The following is a description of a gene set: Genes predicted to be targets of miRBase v22 microRNA hsa-miR-595 in miRDB v6.0 with MirTarget v4 prediction scores > 80 (high confidence targets). Human Gene Set: MIR595 from publication Chen Y, Wang X (PMID 31504780) species: Homo sapiens, and this is the list of marker genes: KIAA0753, RGN, ODC1, ZNF845, AKR1C2, TRAPPC13, CSMD3, IFNA14, SLC19A1, NTS, ETFRF1, HIVEP1, OGA, FAM227A, AFF4, PLD5, CLOCK, HINT1, UBE2G2, ARHGAP1, PPP3CA, BCAR3, NR2F2, DENND5A, ZDHHC13, CHM, SLCO4C1, UBASH3B, GAB4, CCDC85C, ECT2L, PPP1R21 (protein phosphatase 1 regulatory subunit 21), ZFP91, SH3YL1, SCLT1 (sodium channel and clathrin linker 1), CUL5, KIF21A (NCBI Gene Id 80819), KMT5A, COQ10B, IARS1, ADIPOR1, MTMR10, BNIP2, GABRA1, REPS2, ARMC8, OPHN1, HSF5, HAS2, BCKDHB, ROCK2, SFMBT1, SLC30A8, SERTM1, NCAM1, IFNA7, MLANA, USP10 (ubiquitin specific peptidase 10), IFNA17, IGF1, SUCO, MED13L, BEST3, CLTB (clathrin light chain B), DUXA, SPRED1, YES1